The following is a description of a gene set: A process that is carried out at the cellular level which results in the assembly, arrangement of constituent parts, or disassembly of cytoskeletal structures comprising neurofilaments and their associated proteins. Human Gene Set: GOBP_NEUROFILAMENT_CYTOSKELETON_ORGANIZATION species: Homo sapiens, and this is the list of marker genes: ATF2, NEFL, CLN8, SOD1, ARHGEF28, ATP8A2 (ATPase phospholipid transporting 8A2), INA, VPS54, NEFH, NDEL1